The following is a description of a gene set: from publication Nakaya HI, Clutterbuck E, Kazmin D, Wang L, Cortese M, Bosinger SE, Patel NB, Zak DE, Aderem A, Dong T, Del Giudice G, Rappuoli R, Cerundolo V, Pollard AJ, Pulendran B, Siegrist CA (PMID 26755593) The dynamics and molecular mechanisms underlying vaccine immunity in early childhood remain poorly understood. Here we applied systems approaches to investigate the innate and adaptive responses to trivalent inactivated influenza vaccine (TIV) and MF59-adjuvanted TIV (ATIV) in 90 14- to 24-mo-old healthy children. MF59 enhanced the magnitude and kinetics of serum antibody titers following vaccination, and induced a greater frequency of vaccine specific, multicytokine-producing CD4(+) T cells. Compared with transcriptional responses to TIV vaccination previously reported in adults, responses to TIV in infants were markedly attenuated, limited to genes regulating antiviral and antigen presentation pathways, and observed only in a subset of vaccinees. In contrast, transcriptional responses to ATIV boost were more homogenous and robust. Interestingly, a day 1 gene signature characteristic of the innate response (antiviral IFN genes, dendritic cell, and monocyte responses) correlated with hemagglutination at day 28. These findings demonstrate that MF59 enhances the magnitude, kinetics, and consistency of the innate and adaptive response to vaccination with the seasonal influenza vaccine during early childhood, and identify potential molecular correlates of antibody responses. Genes up-regulated in peripheral blood mononuclear cell 1d postboost vs 0d pre-imm in children (14-27m) after exposure to Imuvac, time point 1D. Comment: TIV Human Gene Set: NAKAYA_PBMC_IMUVAC_MALE_AGE_14_27YO_1D_POSTBOOST_VS_0DY_PREIMM_TIV_UP species: Homo sapiens, and this is the list of marker genes: P2RY14, IRF1, NOD2, FCGR1A, WARS1, SLC4A1, CTSW, PSTPIP2, VSTM1, PTGDR2, LPCAT2, PSMF1, GBP1, SNX27, FKBP5, GK3, RAB20, UCP2, SERPING1, PI3, ICAM1, MS4A3, GBP5, BATF2, CD274, RAPGEF2, IGLV4-60 (NCBI Gene Id 28785), ADORA3, PRSS33, GK, IDO1, TSPAN5, FCGR1BP, TMOD1, SIRPB1, PRRG4, TNFAIP2, KREMEN1, ATP6V0C, CCR3, ETV7, ANKRD22, GBP4, FAS